Given this list of marker genes Slamf6 (NCBI Gene Id 80894), Ulbp1, Gimap3, Klrc2, Ap1g1, Il18rap, Dpp4, Lamp1, Clnk (cytokine-dependent hematopoietic cell linker), Klri1, Klrk1, Vav1, Klre1, Rasgrp4, Cd160, Il21, Klrc3, H2-M3, H2-T23, Stat5a, Raet1d, Il12a, Klrc1, Pvr, Cadm1, Sh2d1b2, Klrb1c, Cd226, Crtam, Ncr3-ps, Sh2d1a, Raet1e, Gimap5, Rasgrp1, Sh2d1b1, Nectin2, Il12b, Klri2, Stat5b, Klrd1 (NCBI Gene Id 16643), Lag3, here is a description of the gene set: Any process that activates or increases the frequency, rate, or extent of natural killer cell mediated immunity. studied in species Mus musculus Mouse Gene Set: GOBP_POSITIVE_REGULATION_OF_NATURAL_KILLER_CELL_MEDIATED_IMMUNITY